Given this list of marker genes Lyn, Prss22, Aph1c, Grn, Efna1, Ctsh, Ncstn, Cldn4, Rcn3, Efna3 (ephrin A3), Stat3, Vcp, Vsir, Ddrgk1, Epha4, Aph1a, Psenen, Antxr1, Aph1b, Ager, Mbp, Cldn13, Cldn3, Prelid1, Sfrp2, Tank, here is a description of the gene set: Mouse Gene Set: GOBP_POSITIVE_REGULATION_OF_PEPTIDASE_ACTIVITY studied in species Mus musculus Any process that increases the frequency, rate or extent of peptidase activity, the hydrolysis of peptide bonds within proteins.